The following is a description of a gene set: Enables the transfer of riboflavin from one side of a membrane to the other. Riboflavin (vitamin B2) is a water-soluble B-complex vitamin, converted in the cell to FMN and FAD, cofactors required for the function of flavoproteins. studied in species Mus musculus Mouse Gene Set: GOMF_RIBOFLAVIN_TRANSMEMBRANE_TRANSPORTER_ACTIVITY, and this is the list of marker genes: Rtbdn, Slc52a2, Abcg2, Slc52a3, Slc22a14, Abcg3